The following is a description of a gene set: Any process that stops, prevents, or reduces the frequency, rate, or extent of interleukin-13 production. Mouse Gene Set: GOBP_NEGATIVE_REGULATION_OF_INTERLEUKIN_13_PRODUCTION species: Mus musculus, and this is the list of marker genes: Tnfrsf21, Lef1, Lilra5, Arg2, Scgb1a1